Given this list of marker genes XACT, HSPA6, TASL, ARL4AP5 (ADP ribosylation factor like GTPase 4A pseudogene 5), SLC9A9-AS1, RTTN, PTER, DOCK8, LY96, CHI3L1, LPIN2, MTAPP2, SERPINF1, FCGR3A, ACP3 (NCBI Gene Id 55), LAT2, CPVL, MANBA, TRIM50, LINC-PINT, NFKBID, ALDH1A3-AS1, CLEC7A, RNASE6, CASP5, GAPT (GRB2 binding adaptor protein, transmembrane), ARHGAP15, LINC02117, TMC8, PFDN1P1, GPR34 (G protein-coupled receptor 34), GAL3ST4, APOC1P1, RPS6KA1, CACNA2D4, KCNJ5-AS1, PDCD1LG2, C1QA, RYR1, RN7SL138P, RN7SL297P, RNU5E-1, GAB3, FBXO34-AS1, SHISAL2A, FCAR, TMIGD2, SLC2A5, GBP2, APOBR, IL17RA, CTSC, LILRA2, LILRA6, RPH3AL-AS1, RNU4-62P, NPM1P10, EGR2, CX3CR1, IL18, IPCEF1, CHORDC1P4, LRRK1, LINC02985, FCGR1A, SASH3, SOWAHD, IL10, ENSG00000249738, AIDAP2, TLR7 (toll like receptor 7), RN7SL834P, STYXL2, LINC01645, S100A1, ADAM28, HAMP, GPR132, CCR1, PLCG2, PPARG, SCIN, BLVRB, MROCKI, DOCK8-AS1, LILRB5, SOCS6, LILRA1, MKNK1, LINC01909, ACSM5, MS4A4A, TFCP2L1, SLC25A24P1, APOC4, SAMSN1, BIN1, LAIR1, ELL2, SLC11A1, LILRB1, GPN3, ITGAX, MNDA, GLIPR1, IL6R-AS1, GNG7 (NCBI Gene Id 90274), LILRB3, SIGLEC16, HOMER3-AS1, CD48, CLEC9A, AOAH-IT1, CARD14, CSF2RB, EXPH5, ITGAM, VAV1, CCDC200, RPL34P19 (ribosomal protein L34 pseudogene 19), TMEM156, SLC7A7, CXCL16, H2BP2, SPATC1, NPL, GPR183, FGF20, AP1B1, CTSB, DHRS9, ST13P15, RPS23P6, MS4A14, ERMAP, GBGT1, ATG7 (NCBI Gene Id 105376952), SPI1, SLC47A1, PRAM1, HLA-DMB (NCBI Gene Id 3109), ACY3, LINC02712, CORO1A, POM121B, GYPC, AIF1, DENND1C, LINC01480, SERPINA1, BATF3, HISLA, IL12RB1, MPEG1, CD83, PPP1R2P4, FMNL1, CDKN2A, MRPL42P6, ZNF710, CLEC19A, PLD4, ENSG00000234132, P2RY12 (purinergic receptor P2Y12), ARHGAP9, RAB42, PLD1, HMGA1P4, DOCK4, ALPK1, MEFV, GPBAR1, GOT2P7, LINC02109, ARHGAP24, CSF1, RNU7-181P, LY86-AS1, ARL5C, GALNT6, HMOX1 (NCBI Gene Id 3162), ADRB2, DDX43, NAIP, ZC3H12D, CD4, TRPM2, LINC00539, LGMN, SLFN11, PDK4 (NCBI Gene Id 5166), CCR3, RGS1, CD68, GPRC5D, IGSF10, TLR5, TMIGD3, SNRPD2P1, MRC1, FMN1, AOAH, SLC37A2, IFI30, ADAP2, LILRB2, GCLC, GCNT2, LINC01141, SLFN13, ENTPD1, LINC02953, LINC00278, MS4A6A, TLR1, HRH1, SFMBT2, IL1B, SUCNR1, CD5L, ST14, FCGR1BP, CALCB, PPT1, SLC29A3, APBB1IP, PIK3R5, LINC00671, RNF149, FCGR2C, GPR84, IL1A, TREM1, DUSP29, LINC01736, GLDN, PCED1B-AS1, RGL3, LRMDA, TYROBP, CD74, SIGLEC11 (sialic acid binding Ig like lectin 11), CD163, LINC02381, LILRB4, PTPRN2-AS1, CH25H, MYO1F, PDXP-DT, ALDH3B1, BVES-AS1, TLR4, EDNRB-AS1, TYMP, LINC03070, RN7SL172P, LINC01768, CHIT1, RPS15AP29, PRRG4, GNB4, FAM238A, HFE, CARD11, RAB20, FGL1, H2BC18 (H2B clustered histone 18), ARHGAP12, STEAP1B (NCBI Gene Id 402466), FOLR2, SPP1, SP140, MYOZ2 (NCBI Gene Id 53348), CD300LF, CAPG, LINC01160, C19orf38, LINC02642, VSIG4, SYNDIG1, SPTLC3, RAP1A, TRAF3IP3 (NCBI Gene Id 80342), FGD2, RNPS1P1, CTSS, TRIM22, APOC1, LRRC18, CASP1, B4GALT1, LINC00996, GTSF1, RNU7-29P (NCBI Gene Id 124904769), RPS10-NUDT3, ATP8B4, WFDC8, PARVG, TMCO4, NINJ1, LPCAT2, IRF8, PTPN22, MR1, DOCK2, SNX29, MAST3, CREG1, ZMYND15, BHLHE41, LINC02798, ENSG00000258168 (NCBI Gene Id 105369828), CSF1R, PCK2, CD33, ZNF812P, OSCAR, RUNX2, RIN3, IL13RA1, TNFAIP8L2, HK2, HMGB1P21 (NCBI Gene Id 100419947), SYT9-AS1, COL8A2, LINC01684, ABCC13, TNFRSF11A, PDYN-AS1, HK3, EGR3, LIMASI, TREM2, NCF2, HGF (NCBI Gene Id 317720), CD37, MYO7A, LINC01678, TAGAP, RCN3, CCDC88B, MAF, TMEM106A, GSN-AS1, OSM, EBI3, MERTK, PNPT1P1 (NCBI Gene Id 100293885), SIGLEC5, DPRXP4, SLC17A9, SLC39A13-AS1, MKNK1-AS1, TLR3, SLC28A1, RPA4, GDPD4, MORC1, ARHGAP27P1-BPTFP1-KPNA2P3, CEACAM21, TNFSF13, ARHGAP30, LINC01235, SNORD89, BCL2A1, UNC93B1, TMEM86A, CD180, IL1RN, S100A9, SULT1C2, ARRDC5, IRF5, RPL7AP42, SMIM35 (NCBI Gene Id 107984395), IL7R, BVES, CDKN2B-AS1 (CDKN2B antisense RNA 1), PDE4DIPP3, HPGDS, LINC02611, C12orf75, LINC00649, C5AR1, TMEM144, LINC01845, TFEC, BNC2, SNORD11, TMEM52B, SLC38A4, CSF3R, MYO1G, ENSG00000232053, MS4A7, MILR1, SELPLG, SIRPB1, SLC15A3, ARRB2, PDE4DIPP7, ITGB2-AS1, CLEC17A, RBM47, ASTL, COX6CP17, P2RY8, LGALS3, IRF4, KCNK13, ENSG00000231204, P3H2, B3GNT5, PLVAP, PLA2G7, LINC03002, WDFY4, ITGAD, CYTIP, CSF2RA, CYTH4, GPNMB, LINC01375, MGAT4A, P2RX4, MEP1A, LNCAROD, LY86, SIGLEC10, HAVCR2, LILRB1-AS1, ITGB2, P2RY13, ADAMTSL4-AS2, ARL11, NFAM1 (NFAT activating protein with ITAM motif 1), ALOX15B, C1QC, ADA2 (adenosine deaminase 2), SIGLEC8, LY75, NCF1 (NCBI Gene Id 653844), C5AR2, CRYBB1, LRRC39, ENSG00000232884, LYZ, TNFSF18, EML4-AS1 (NCBI Gene Id 102723824), NLRC4, LINC01504, TRIM34, H2BC4, TMEM273 (NCBI Gene Id 170371), SMAP2, ADPGK, RAB39A, GGTA1, SERPINB9P1, ITGAL, SYT6, HCLS1, MAP3K5-AS1, RNU2-63P (RNA, U2 small nuclear 63, pseudogene), CD28, TRPM2-AS, CD86, PIK3AP1 (NCBI Gene Id 118788), CEP250-AS1, P2RY6, NFATC2, BATF, OSBPL11, GPR65, ANXA2R-AS1, TLR2, SPNS3, UAP1L1, OAS1, RASGRP4, KPNA2P3, HAVCR1, BLNK, PRR13P5, PDCD1, TNFSF8, CYSLTR1, ERP27, CEBPA (CCAAT enhancer binding protein alpha), CYBB, RN7SL368P, LRRC25, NCF4, TBC1D12, LYVE1, ENSG00000249631, OTULINL, S100Z, DENND2D, SMC1B, AMPD3, KIR3DX1, DIAPH2, MEPE, C2, LILRA4, SIGLEC14, CEP295NL, STEAP1B-AS1, S100A8, COL6A4P2, CHEK2, EVI2B, IGFLR1, MYO1A, CARD9 (NCBI Gene Id 64170), here is a description of the gene set: The gene expression program underlying the specification of human cell types is of fundamental interest. The study authors generated human cell atlases of gene expression and chromatin accessibility in fetal tissues. For gene expression, the study authors applied three-level combinatorial indexing to >110 samples representing 15 organs, ultimately profiling ~4 million single cells. The study authors leveraged the literature and other atlases to identify and annotate hundreds of cell types and subtypes, both within and across tissues. Our analyses focused on organ-specific specializations of broadly distributed cell types (such as blood, endothelial, and epithelial), sites of fetal erythropoiesis (which notably included the adrenal gland), and integration with mouse developmental atlases (such as conserved specification of blood cells). These data represent a rich resource for the exploration of in vivo human gene expression in diverse tissues and cell types. Human Gene Set: DESCARTES_FETAL_CEREBRUM_MICROGLIA Marker genes curated from the annotated cluster as represented in the Descartes Human Gene Expression During Development database. studied in species Homo sapiens from publication Cao J, O'Day DR, Pliner HA, Kingsley PD, Deng M, Daza RM, Zager MA, Aldinger KA, Blecher-Gonen R, Zhang F, Spielmann M, Palis J, Doherty D, Steemers FJ, Glass IA, Trapnell C, Shendure J (PMID 33184181)